Given this list of marker genes ADIPOQ, PHF14, CBL, IFT20, CBLB, here is a description of the gene set: species: Homo sapiens Human Gene Set: GOBP_REGULATION_OF_PLATELET_DERIVED_GROWTH_FACTOR_RECEPTOR_ALPHA_SIGNALING_PATHWAY Any process that modulates the frequency, rate or extent of platelet-derived growth factor receptor-alpha signaling pathway.